The following is a description of a gene set: Genes negatively differentially expressed in cell type: NK cell upon treatment with cytokine: IFN-ε in mouse lymph nodes in vivo. species: Mus musculus Mouse Gene Set: CUI_NK_CELL_IFNE_RESPONSE_DN Cytokines mediate cell-cell communication in the immune system and represent important therapeutic targets. A myriad of studies have highlighted their central role in immune function, yet we lack a global view of the cellular responses of each immune cell type to each cytokine. To address this gap, the authors created the Immune Dictionary, a compendium of single-cell transcriptomic profiles of more than 17 immune cell types in response to each of 86 cytokines (>1,400 cytokine-cell type combinations) in mouse lymph nodes in vivo. A cytokine-centric view of the dictionary revealed that most cytokines induce highly cell-type-specific responses. For example, the inflammatory cytokine interleukin-1β induces distinct gene programmes in almost every cell type. A cell-type-centric view of the dictionary identified more than 66 cytokine-driven cellular polarization states across immune cell types, including previously uncharacterized states such as an interleukin-18-induced polyfunctional natural killer cell state. from publication Cui A, Huang T, Li S, Ma A, Pérez JL, Sander C, Keskin DB, Wu CJ, Fraenkel E, Hacohen N (PMID 38057668), and this is the list of marker genes: Cd28, Emb, Hspa1a, Ets1, Rgs1, Dusp1, Il18r1, Fosb, Tcf7, Jun, Cd7, Il7r, Fos, Klf6, Uba52